The following is a description of a gene set: studied in species Mus musculus Mouse Gene Set: GOCC_CONTRACTILE_RING A cytoskeletal structure composed of filamentous protein that forms beneath the membrane of many cells or organelles, in the plane of cell or organelle division. Ring contraction is associated with centripetal growth of the membrane that divides the cytoplasm of the two daughter cells or organelles., and this is the list of marker genes: Pdxp, Alkbh4, Pstpip1, Rtkn, Septin2, Bloc1s6, Maea, Utrn, Prc1, Anln, Kif20b (NCBI Gene Id 286943), Myh2, Dag1, Myh9